The following is a description of a gene set: part of: Hemostasis The crosslinked fibrin multimers in a clot are broken down to soluble polypeptides by plasmin, a serine protease. Plasmin can be generated from its inactive precursor plasminogen and recruited to the site of a fibrin clot in two ways, by interaction with tissue plasminogen activator at the surface of a fibrin clot, and by interaction with urokinase plasminogen activator at a cell surface. The first mechanism appears to be the major one responsible for the dissolution of clots within blood vessels. The second, although capable of mediating clot dissolution, may normally play a major role in tissue remodeling, cell migration, and inflammation.<br>Clot dissolution is regulated in two ways. First, efficient plasmin activation and fibrinolysis occur only in complexes formed at the clot surface or on a cell membrane - proteins free in the blood are inefficient catalysts and are rapidly inactivated. Second, both plasminogen activators and plasmin itself are inactivated by specific serpins, proteins that bind to serine proteases to form stable, enzymatically inactive complexes.<br>These events are outlined in the drawing: black arrows connect the substrates (inputs) and products (outputs) of individual reactions, and blue lines connect output activated enzymes to the other reactions that they catalyze. species: Homo sapiens Reactome Pathway: Dissolution of Fibrin Clot, and this is the list of marker genes: ANXA2, PLG, S100A10, PLAUR, SERPINB8, SERPINB6, PLAU, SERPINB2, SERPINE2, SERPINF2, PLAT, HRG, SERPINE1